Given this list of marker genes Slc39a5, Slc4a8, Slc39a4, Slc39a14, Slc39a6, Slc4a10, Slc4a4, Slc39a10, Slc39a12, Slc4a5, Slc4a9, Slc4a7, Slc39a8, here is a description of the gene set: species: Mus musculus Mouse Gene Set: GOMF_MONOATOMIC_CATION_BICARBONATE_SYMPORTER_ACTIVITY Enables the transfer of a solute or solutes from one side of a membrane to the other according to the reaction: monoatomic cation(out) + HCO3-(out) = monoatomic cation(in) + HCO3-(in).